Given this list of marker genes Efna1, Reln, Lilrb4b, Fbxw7, Ptprc, Aplp2, Agrn, Ggnbp2, Socs4, Agt, Gprc5a, Rap2b, Cblc, Lilrb4a, Chmp6, Dok7, Adam17, Gprc5b, Abi3, Hyal2, Il34, Errfi1, Abi1, Psen2, Csf1r, Abi2, Mvp, Tsg101, Nox4, Psen1, Unc119, Socs5, Dusp22, Ptpn2, Cass4, Cav1, Lilra5, Ptpn1, Rap2c, Dvl2, Grem1, Neurl1a, Egf, Itgb3, Zgpat, Nedd9, Wnt3a (NCBI Gene Id 22416), Srcin1, App, Zfyve28, Ptk6, Vps25, here is a description of the gene set: Any process that modulates the rate, frequency, or extent of protein tyrosine kinase activity. species: Mus musculus Mouse Gene Set: GOBP_REGULATION_OF_PROTEIN_TYROSINE_KINASE_ACTIVITY